Given this list of marker genes MPZ, SLC25A21, DAO, GLT8D1, MATR3, ATP1A2, EXOSC8, PRX, TBK1, RMND1 (required for meiotic nuclear division 1 homolog), EGR2, ANG, NEK1, FXR1, PON2, UBA1, SQSTM1, AGTPBP1, CFAP410, ERBB4, NOP56, EXOSC9, HNRNPA1, ADPRS, PON3, CHMP2B, PRRT2 (proline rich transmembrane protein 2), PPARGC1A, PRPH (peripherin), TSPYL1, VAPB, SLC25A46, SOD1, SLC52A3, CACNA1A, DCTN1, VWA1, SMN1, TBCD, MEGF10, PMP22, GLE1, EXOSC3, TREM2, OPTN, FUS, UBQLN2 (ubiquilin 2), LGI3, SPTLC1, SLC52A2, SMN2 (survival of motor neuron 2, centromeric), TOE1 (target of EGR1, exonuclease), NDUFS4, UNC13A, VRK1, TARDBP, KCNK9, SYT2, CCNF, PON1, SCN1A, AIFM1, PFN1, PRUNE1, FIG4, TAF15, ASAH1, ANXA11, ATP11A, VCP, CHCHD10, SH3TC2, ATXN2, NEFH, here is a description of the gene set: Tongue fasciculations Fasciculations or fibrillation affecting the tongue muscle. species: Homo sapiens Human Gene Set: HP_TONGUE_FASCICULATIONS